Given this list of marker genes TUBB8B, RPS6KA6, RPS6KA2, TUBB3, TUBAL3, PRKAG1, GRIA1, LRRC7, PRKACG, TUBB1, TUBA1C, DLG4, CREB1 (cAMP responsive element binding protein 1), GRIA2, APBA1, PRKAR2B, GRIN3A, DLG2, RPS6KA3, PRKAB2, ERBB4, RASGRF2 (Ras protein specific guanine nucleotide releasing factor 2), TUBA4B, RASGRF1, PRKX, CAMKK1, GRIN2C, GRIA3, GRIN2D, KIF17 (kinesin family member 17), PRKACA, NBEA, PRKAA1, TUBA1A, TUBB2B, NRG1, TUBB6, ADCY1 (NCBI Gene Id 449484), TUBA4A, GIT1, GRIN2A, PRKACB, DLG3, TUBB4A, CAMK2D, ARHGEF7, SRC, CAMK4, PRKAR2A, TUBA8, TUBA3E, PPM1F, PRKAA2, PRKAR1A, MAPK3, MAPT (NCBI Gene Id 8152), CASK, DLG1, GRIN1, CAMK2B, KPNA2, LIN7B, TUBA3D, TUBB4B, TUBB8, CAMK2G, LIN7C, RPS6KA1, GRIN2B, PDPK1, MAPK1, NRGN, TUBB2A, ACTN2, TUBA1B, CAMKK2, PRKAR1B, NEFL, GRIA4, CALM1, NRAS, CAMK2A, PPM1E, HRAS, CAMK1, GRIN3B, TUBA3C, RAC1, PRKAB1, ADCY8, LIN7A, KRAS, PRKAG2, PRKAG3, here is a description of the gene set: studied in species Homo sapiens Reactome Pathway: Activation of NMDA receptors and postsynaptic events NMDA receptors are a subtype of ionotropic glutamate receptors that are specifically activated by a glutamate agonist N-methyl-D-aspartate (NMDA). Activation of NMDA receptors involves opening of the ion channel that allows the influx of Ca2+. NMDA receptors are central to activity dependent changes in synaptic strength and are predominantly involved in the synaptic plasticity that pertains to learning and memory. A unique feature of NMDA receptors, unlike other glutamate receptors, is the requirement for dual activation, both voltage-dependent and ligand-dependent activation. The ligand-dependent activation of NMDA receptors requires co-activation by two ligands, glutamate and glycine. However, at resting membrane potential, the pore of ligand-bound NMDA receptors is blocked by Mg2+. The voltage dependent Mg2+ block is relieved upon depolarization of the post-synaptic membrane. NMDA receptors are coincidence detectors, and are activated only if there is a simultaneous activation of both pre- and post-synaptic cell. Upon activation, NMDA receptors allow the influx of Ca2+ that initiates various molecular signaling cascades involved in the processes of learning and memory. For review, please refer to Cohen and Greenberg 2008, Hardingham and Bading 2010, Traynelis et al. 2010, and Paoletti et al. 2013. part of: Neurotransmitter receptors and postsynaptic signal transmission